Given this list of marker genes PPOX, ACAA1, ACOX1, RSAD1, ACOXL, CPOX, ACOX3, ACOX2, CRAT, here is a description of the gene set: Catalysis of an oxidation-reduction (redox) reaction in which a CH-CH group acts as a hydrogen or electron donor and reduces oxygen. species: Homo sapiens Human Gene Set: GOMF_OXIDOREDUCTASE_ACTIVITY_ACTING_ON_THE_CH_CH_GROUP_OF_DONORS_OXYGEN_AS_ACCEPTOR